Given this list of marker genes IL19, NPY, SMPD3, GPX5, TRIM31, MTSS1, L3MBTL1, CDKN1C, NGFR, CNR2, DAPK2, TACSTD2 (NCBI Gene Id 4070), CSF2, H4C12, PRSS16, SMG1P5, WNT1, RFC1, CHIT1 (chitinase 1), EMP1, here is a description of the gene set: studied in species Homo sapiens from publication de Nigris F, Rossiello R, Schiano C, Arra C, Williams-Ignarro S, Barbieri A, Lanza A, Balestrieri A, Giuliano MT, Ignarro LJ, Napoli C (PMID 18339860) Genes up-regulated in SaOS-2 cells (osteosarcoma) upon knockdown of YY1 by RNAi. We know that the Yin Yang 1 protein (YY1) overexpression is positively and strongly correlated with the degree of malignancy of bone tumors. Therefore, we questioned whether we could influence cell invasiveness by deleting YY1 in human osteosarcoma cells (SaOs-2), as tested in Matrigel-coated filters and metastasis implantation of such osteosarcoma cells in vivo, by serial analysis with nuclear magnetic resonance. Moreover, we focused our work on the chemokine receptor CXCR4 and its inhibition by T22 antibody, as well as on systemic (direct in vivo assay) and computer-assisted imaging of angiogenesis-related metastasis. Results showed that cell invasiveness and metastasis implantation by wild-type SaOs-2 cells, as evaluated by histology and immunohistochemistry, are associated with up-regulation of CXCR4 expression, which in turn was significantly reduced by T22. In addition, deletion of YY1 (siRNAYY1-SaOs-2) induced a significant decrease of cell invasion and metastasis growth. This phenomenon was associated with decreased vascular endothelial growth factor (VEGF)/angiogenesis and a complex rearrangement of the gene expression profile as evaluated by microarray analysis. In conclusion, YY1 and VEGF/CXCR4 seem to intervene in the pathogenesis of the malignant phenotype of osteosarcoma by acting on cell invasiveness and metastasis growth. Human Gene Set: DE_YY1_TARGETS_UP